Given this list of marker genes Ces1h, Gramd1a, Lrp8, Smad2, Tgfbr1, Lrp6, Ces1c, Abca1, Ces1d, Ces1e, Gramd1b, Gramd1c, Nfe2l1, Ces1b, Tgfbr2, Cyp7a1, Ccr5, Tgfb1, Ccl3, Ptch1, F7, Osbpl7, Mlc1, Gpr155, Ces1a, Inhba, Dag1, Inhbb, Ces1g (NCBI Gene Id 12623), Smo, Ces1f, Pmvk, Gpld1, here is a description of the gene set: Mouse Gene Set: GOBP_RESPONSE_TO_CHOLESTEROL species: Mus musculus Any process that results in a change in state or activity of a cell or an organism (in terms of movement, secretion, enzyme production, gene expression, etc.) as a result of a cholesterol stimulus.